The following is a description of a gene set: part of: Signal Transduction Reactome Pathway: Signaling by Receptor Tyrosine Kinases electronically inferred by orthology from the curated human pathway species: Mus musculus This event has been computationally inferred from an event that has been demonstrated in another species.<p>The inference is based on the homology mapping from PANTHER. Briefly, reactions for which all involved PhysicalEntities (in input, output and catalyst) have a mapped orthologue/paralogue (for complexes at least 75% of components must have a mapping) are inferred to the other species., and this is the list of marker genes: Lck, Fgf22, Ranbp10, Pdgfrb, Muc20, Frs2, Thbs3, Stam, Hgf, Rictor, Ptpn12, Fgfbp3, Atp6v1a, Hgfac, Ptn, Fgf10, Hras, Col9a1, Cdh5, Epgn, Col4a2, Ltk, Vrk3, Ptk2, Spint1 (serine protease inhibitor, Kunitz type 1), Vegfd, Fam83b, Spry1, Lama4, Gga3, Irs2 (insulin receptor substrate 2), Psenen, Prkacb, Vav1, Col6a6, Ptbp1, Egr2, Fgfrl1, Fam83a, Mapk14, Egfr, Atp6v0e2, Prkca, Fgf15, Itga2 (NCBI Gene Id 16398), Atp6v1d, Ptpn1, Mapk12, Atp6v0a1, Alk, Vegfb, Flrt2, Ppp2r1b, Plg, Cbl, Stat5a, Fgf1, Fyn, Nrg3, Dusp7, Polr2a (NCBI Gene Id 20020), Eps15l1, Gtf2f2, Polr2i, Them4, Prkaca (NCBI Gene Id 18747), Pxn, Ap2b1, Ptpn2, Mst1, Shc1, Polr2l, Areg, Flrt1, Kitl, Jup, Fgfr1, Cdc42, Arf6, Map2k2 (NCBI Gene Id 26396), Ntf5, Mdk, Fgf7, Ctsd, Pag1, Ptprf, Sh3gl3, Cma1, Sgk1, Spry2, Ptpn18, Wasf3, Pik3cb, Gtf2f1, Shc2, Crk, Flt3l, Bcar1, Ap2s1, Fgf17, Rps6ka5, Mapk13, Polr2k, Btc, Igf2, Hpn, Fgf20 (NCBI Gene Id 80857), Vegfa, Col5a3, Axl, Atp6ap1, Ap2m1, Atp6v1c2, Rasa1, Ncf2, Fgf6, Polr2f, Polr2c (polymerase (RNA) II (DNA directed) polypeptide C), Irs1, Tlr9 (NCBI Gene Id 81897), Flt1, Ncf1, Epn1, Fgf5, Wasf1, Pdgfd, Tns4, Shc3 (NCBI Gene Id 20418), Ep300, Fgfbp1, Cilp, Pcsk5, Tec, Atp6v1g2, Atp6v0a4, Tgfa, Mapk11, Ptpn3, Yap1, Grap2, Cdc37, Cav1, Pdpk1, Erbb2, Fgf8, Arhgef7, Kl, Sh2b3, Irs4, Pdgfb, Ins2, Ap2a1, Gab1, Ptpn6, Col11a2, Pik3c3, Jak3, Atp6v1e2, Esr1, Erbb4, Thbs2, Ctnnb1, Ngf, Atp6v1f, Stat5b, Rps27a, Klb (NCBI Gene Id 83379), Shb, Atp6v1g3 (ATPase, H+ transporting, lysosomal V1 subunit G3), Fgf2 (NCBI Gene Id 14173), Kidins220, Pak3, Psen1, Atp6v0c, Csk, Flt4, Polr2e, Col2a1, Pik3r2, Tcirg1, Alkal2, Ranbp9, Rab4a, Kit, Hspb1, Fgf23, Grap, Fgf16, Calm1, Spp1, Map2k1, Cyfip2, Cyba, Fgf4, Ins1, Grb2, Hdac3, Thbs4, Vegfc, Fes, Mapk7, Col6a5, Bdnf, Mapk3 (NCBI Gene Id 26417), Yes1, Itga3, Atp6v0e, Pdgfa, Memo1, Dusp6, Col6a1, Pgf, Atp6v0d1, Ptprk, Ralgds, Ubb, Gipc1, Ppp2r5d, Col24a1, Polr2b, Matk